The following is a description of a gene set: Mouse Gene Set: MIR_543_3P Genes predicted to be targets of miRBase v22 microRNA mmu_miR_543_3p in miRDB v6.0 with MirTarget v4 prediction scores > 80 (high confidence targets). species: Mus musculus from publication Chen Y, Wang X (PMID 31504780), and this is the list of marker genes: Nmt2, Rbm26, Osbpl3, Hephl1, Zfp874a, Dnal1, Zfp503, Rad21, Nwd2, Rabgef1, Dync1li2, Drd1, Twist1 (NCBI Gene Id 22160), Rassf10, Elovl2, Grm8, Atad5, Prl6a1, Tnfsf11, Zbtb43, Pla2g4a, Pdap1, Lhx9, Akap6, Fign, Gramd4, Ercc8, Eps8, Hprt1, Nmnat3, Tgfbi, Gpbp1, Gm6710, B3galt5, Hspa12a, Fcho2, Fndc3b, Dclk1, Myot, Cadm2, Capza1, Pcdh9, Plppr4, Lmbrd1, Adam9, Clock, Nr1d2, Fzd4 (frizzled class receptor 4, NCBI Gene Id 14366), Creb1, Hmgb1, Eif5a2, Asxl3, Sirt1, Api5, Khdrbs1, Katnbl1, E2f7, Marchf6 (membrane associated ring-CH-type finger 6), Itch, Cblb, Ing1, Cpeb4, Grik2, Fam117a, Cdh2, Armc8, Slc34a2, Pank3, Txlnb, Tmem126b, Slc40a1, Zfp711, Cdc7, Sorcs1, Agr2, Onecut2, Ahcyl (adenosylhomocysteinase like), Atf7ip2, Zfp131, Senp1, Syne1, Clasp2, Ptprb, Kcna4, Fhip1a, Rnf138, Kcns2, Naaladl2, Ankrd13c, Pwp1, Ppp2r2c, Pbsn, Pcsk5, Il1a (NCBI Gene Id 16175), Mysm1, Tbc1d1 (NCBI Gene Id 79105), Rnf103, Phip, Prtg, Adgrb3 (NCBI Gene Id 210933), Runx1t1, Zfp616, Pcf11 (PCF11 cleavage and polyadenylation factor subunit), Slc39a12, Zfhx4, Zfp280d, Id4, Nr3c1, Cdh8, Cggbp1, Senp2, Fnip2, Matr3, Dhx15, Ifi208, Rbm46, Cyp2c39, Zfp991, Msl3, Mtf2, Bltp3b, Npm1, Rcbtb2, Eif4a2, Klf6, Bicd1, Oat, Cacnb4, Cox11, Gpr155, Mre11a, Arl13b, Naa20, Rassf8 (NCBI Gene Id 71323), Ppp4r3b, Snx16, Dgkb, Ube2w, Lmo3, Entrep3, Mapk1, Msl2, Ubl4a (NCBI Gene Id 27643), Rnf2, Atp1b1, Pak5, Lmo1, Arhgef10l, Dmxl1, Brd1, Dock10, Scg2, Cbll1, Plcl1, Cadm1, Mfap3l, Gfpt1, Rpl10l, Palb2, Cysltr1, Zfp874b, Mlf1, Sec62, Or14j9, Eea1, Rasal2, Vcpip1, Ss18l1, Cyp26b1, Spty2d1, Pcdh18, Zfp704, Gm4791, Atl2, Zdhhc17 (zinc finger, DHHC domain containing 17), Myb, Trim36, Mab21l1, Baz2b, Reps2, Zdhhc3, Tcerg1, Sos1, Mettl21e (methyltransferase like 21E), Strbp, Pten, Dlx1, Gpcpd1, Gm14322, Kctd8, Slc12a2, Ccp110, Zfp367, Eya1 (EYA transcriptional coactivator and phosphatase 1), Ereg, Ap4e1, Usp45, Brcc3, Fmnl2, Cdc40, Sh2d3c, Dip2c, Metap1, Jdp2, Zfp931, Nell2, Zfp82, Kcnma1, Msi2 (musashi RNA-binding protein 2), Fkbp4, Kdm5a, Rbm47, Dach1, Ppp3r1, Il1rap, Usp33, Klhl5, Ctdspl, Dmxl2